The following is a description of a gene set: studied in species Mus musculus Mouse Gene Set: GOBP_EYE_MORPHOGENESIS The process in which the anatomical structures of the eye are generated and organized., and this is the list of marker genes: Foxe3, Thrb, Cntf, Bak1, Ntrk2, Sdk2, Hipk1, Cdon, Grcc10, Sox8, Crb2, Mir23a, Poc5, Fjx1, Sp1, Col8a1, Epha2, Samd7, Mfn2, Aqp1, Prdm1, Mir183, Samd11, Vsx2, Ndp, Prom1, Cryaa, Rarb, Atf4, Bhlhe22, Slc1a1 (NCBI Gene Id 319379), Six3, Sp3, Dzank1, Ski, Vhl, Stat3, Rorb, Ephb2 (NCBI Gene Id 13844), Phactr4 (phosphatase and actin regulator 4), Pitx2, Foxl2, Crygb, Ahi1, Mfsd2a, Olfm3, Col5a2, Ttc8, Fasl, Mir96, Otx2, Hipk2, Arid1a, Slc4a7, Rp1, Aqp5, Gabrr2, Bdnf, Ihh, Kdr, Fbn2, Flt1, Rs1, Meis1, Lhx1, Thy1, Sox12, Gnat2, Bbs4, Irx6, Tspan12, Ptprm, Notch2, Calb1, Casz1, Fgf2, Ikzf1, Foxf2, Casp6, Col8a2, Irx5, Tulp1, Nectin1, Vax2os, Man2a1, Ephb1, Hif1a, Dio3, Rho, Miat, Tfap2b, Nectin3, Mir182, Tfap2a, Vegfa, Ptn, Tbc1d20 (TBC1 domain family, member 20), Stra6, Sox11, Dll1, Bmp7 (NCBI Gene Id 12162), Ctnnb1, Alms1, Tsku, Mir124a-1, Gnat1, Notch1, Mfrp, Nf1, Abi2, Nr2e3, Cited2, Mfap5 (NCBI Gene Id 50530), Fgfr3, Bmp4, Rbp4, Lrp5 (NCBI Gene Id 16973), Bhlhe23, Nipbl, Ppp2r3a, Fat1, Hmgn1, Lctl, Gngt1, Gdf11, Aldh1a1, Adamts9, Pdgfb, Cep290, Th, Prox1, Megf11, Agtpbp1, Pde6c, Shroom2, Bax, Tbx2, Rdh13, Sox2, Ring1, Nrl, Bcl2, Ptf1a, Ftx, Frs2, Ift122, Bcar3, Sox1, Rpgrip1l, Fat3, Mir124a-2, Impg2, Crb1, Jag1, Rpgr, Hcn1, Prkci, Fzd5, Tdrd7, Scrib, Vax2, Lrp6, Trpm1, Ush1c, Zeb1, Zhx2, Yy1, Sox9, Bbs10, Mfap2, Dscam, Kdm2b, Foxn4, Stau2, Vsx1, Large1, Rarg, Cabp4, Tenm3, Efemp1, Col5a1, Fbn1, Twist1, Pax2, Rom1, Arl6, Ift172, Aldh1a3, Cnga3, Grk1, Cfh, Gas1, Rpgrip1, Fscn2, Naglu, Pitx3, Pax6, Atp8a2, Sox4, Pou2f1, Tmem215, Gli3, Sdk1